Given this list of marker genes LTBP4, COL1A1, MMP14, FCF1, ADAM12, DHRS1, DNAJC25, PMP22, PLAT, FKBP9, FGF18, COL12A1, ANGPTL2, COL1A2, ISLR, SPARC, ARMCX2, KARS1, GAS1, CRABP2 (NCBI Gene Id 1382), SERPINE2, HCG11, MFGE8, HTRA3, CREB3L1, COL6A6, TMEM39A, ITGB8, PTPMT1, SSPN, MXRA5, MGP, COL14A1, ADAMTSL4, PSENEN, TIMP1, RCN3 (reticulocalbin 3), ASPN, MRC2, TCEAL9, DCN, EMILIN1 (elastin microfibril interfacer 1), EBF2, DLK1, ADAMTSL3, H19, MFAP5, GXYLT2, COL5A1, CHPF, S100A6, SSC5D, CCDC80, FMOD, PLAC9, ZDBF2, FBLN1, GPX8, GJC1, C1R, TENT5A, NCAM1, P3H4, CCBE1, TNS2, LOX, COL5A3, FBN1, SRPX (sushi repeat containing protein X-linked), COL6A1, PI16, C3, CCN3, TSPAN17, CLEC11A, BGN, MMP2 (matrix metallopeptidase 2), NOVA1, MFAP4, SLC39A13, OLFML3, POSTN, PRRX1, FSTL1 (NCBI Gene Id 65385), PDPN, CDK2AP1, HSPB6, COL5A2, IL11RA, SERPING1, FKBP10, OGN, GPC3, ADAMTS5, IGFBP5 (NCBI Gene Id 3488), LRP1, NCAM2, ADAM33, LGALS3BP, SCARA5, CD248, CCDC8, ZNF503, MEST, TSSC4, SEMA3C, CERCAM, ANOS1, NTRK2, FBLN2, LUM, LINGO2, PI15, PCDH7, METRNL, SFRP1, FNDC1, FLNC, MAGED2, ELN, OBSL1, C1S, SFRP2, CKAP4, FBN2, PCOLCE, VCAN, FAM227A, LSP1P4 (NCBI Gene Id 654342), S1PR3, THBS2, IGF2, ADAMTS15, COL3A1, FKBP14, PDGFRA, P4HA2, here is a description of the gene set: from publication Cao J, O'Day DR, Pliner HA, Kingsley PD, Deng M, Daza RM, Zager MA, Aldinger KA, Blecher-Gonen R, Zhang F, Spielmann M, Palis J, Doherty D, Steemers FJ, Glass IA, Trapnell C, Shendure J (PMID 33184181) Marker genes curated from the annotated cluster as represented in the Descartes Human Gene Expression During Development database. Human Gene Set: DESCARTES_FETAL_THYMUS_STROMAL_CELLS The gene expression program underlying the specification of human cell types is of fundamental interest. The study authors generated human cell atlases of gene expression and chromatin accessibility in fetal tissues. For gene expression, the study authors applied three-level combinatorial indexing to >110 samples representing 15 organs, ultimately profiling ~4 million single cells. The study authors leveraged the literature and other atlases to identify and annotate hundreds of cell types and subtypes, both within and across tissues. Our analyses focused on organ-specific specializations of broadly distributed cell types (such as blood, endothelial, and epithelial), sites of fetal erythropoiesis (which notably included the adrenal gland), and integration with mouse developmental atlases (such as conserved specification of blood cells). These data represent a rich resource for the exploration of in vivo human gene expression in diverse tissues and cell types. studied in species Homo sapiens